Given this list of marker genes SLC12A3, FUZ, MTHFR, DLL1, PROKR2, NAA10, HESX1, SOX3, NUAK2, HNF1A, CDON, SIX3 (SIX homeobox 3), ABCC8, FCGR3B, GLI2, HYMAI, SOX2, ARNT2, CLCNKB, PTCH1, MYT1L, CRIPTO, GJA1, CTRC, ZIC2, PLAGL1, SPINK1, DISP1, FGFR1, KCNJ11 (potassium inwardly rectifying channel subfamily J member 11), OTX2, NODAL, ZFP57, GAS1, SUFU, SHH, INTS11, FGF8, FOXH1 (forkhead box H1), VANGL2 (VANGL planar cell polarity protein 2), PPARG, TGIF1, NKX2-5, COL2A1, VANGL1, here is a description of the gene set: Maternal diabetes Human Gene Set: HP_MATERNAL_DIABETES Maternal diabetes can either be a gestational, mostly type 2 diabetes, or a type 1 diabetes. Essential is the resulting maternal hyperglycemia as a non-specific teratogen, imposing the same risk of congenital malformations to pregnant women with both type 1 and type2 diabetes. studied in species Homo sapiens